The following is a description of a gene set: Human Gene Set: GSE3039_ALPHABETA_CD8_TCELL_VS_B2_BCELL_DN from publication Yamagata T, Benoist C, Mathis D (PMID 16623764) studied in species Homo sapiens Genes down-regulated in CD8A CD8B versus B2 B lymphocytes. Three innate (B1-B, NKT, CD8aaT cells) and adaptive (B2-B, CD4T, CD8abT cells) cell-types were sorted by FACS. Three biological replicates for NKT, CD4T, CD8aaT, CD8abT cells and two biological replicates for B1 and B2 cells were generated and the expression profiles were determined using Affymetrix Mu74Av2 chip. Comparisons between the sample groups allow the identification of genes differentially expressed between the innate and adaptive cell-types., and this is the list of marker genes: DYNLT3, IL1R2, NARS2, PLAC1, TNFRSF9, SRSF2, SRM, RMDN3, RARRES2, LOXL1, HOMER1, UQCRB, NUP93, UAP1L1, NFIL3, COQ7, TSC22D1, PRODH, CCL4 (NCBI Gene Id 6351), ACADS, PSMC3, PDE7B, SWI5, AP1B1, EXOC7, PEX11A, METAP2, POLR2D, TRIB2, PVT1, PFKM, ERBB3, EPRS1, MRPS10, KIF24, MCM6, RASSF8, PIGY, WDR12, ADAMTSL4, PPME1, PRDX6, COQ3, AKR1B15, TMEM147, DUSP6, POFUT2, RMDN2, MPHOSPH6, RNF19A, HAL, HSD3B7, TUBA1B, TTC1, MVK, SLC39A1, EBPL, SSX2IP, SLC25A1, FZD1, RENBP, LNX1, NUP88, TNS4, PRSS8, POLR2C, FADS3, HNRNPA1, ATP6V1H, PLAUR, ZNG1B, WDR74, BAIAP2, PSMB4, NUCB2, ARHGAP44, DPAGT1, RALB, PDLIM5, EXT2, SOWAHB, EVA1B, IL1B, PLAAT3, NAA20 (N-alpha-acetyltransferase 20, NatB catalytic subunit), SMURF1, WTIP, PSMD9, QKI (NCBI Gene Id 9444), HAUS1, ENO1, GCAT, DDRGK1, GPSM1, CNNM2, FNIP2, MRPL45, TIMM23, CENPE, RTEL1, BLOC1S5, PRR15, ME1, MYO5A, CENPI, CREB5, PGM1, CLEC5A, AIFM1, ERGIC1, PGF, TMED5, ALG11, MANF, TSG101, FCGR2A, ECHDC3, PEA15, ALKBH2, IL1RN, VPS53, ATIC, CCDC80, SNX8, INHBA (inhibin subunit beta A), SRPRA, APPL2, PPM1J, UBR3, PPP1R14C, LRRC58, MS4A7, ST7L, CHST1, TXNRD1, CLNS1A, TMLHE, NAGLU, MRTFB, TACC3, CENPP, P3H1, ATP7A, CENPS, SRC, TMED1, TADA2A, FUOM, FAM135A, ARHGEF19, GALNT7, IPO5, ELK3, DIO2, DAZAP1, WDR18, MYO1B, NCMAP, ZNF560, CCT2, CD164, METTL1, STMN1, PLEKHF1, DCUN1D3, NOL12, MTBP, BMP2K, ESYT2, COPG1, GARS1 (glycyl-tRNA synthetase 1), HDAC6, IDH2 (NCBI Gene Id 3418), AURKA, DYNC2H1, IGFBP6, LSM2, GINS1, TMEM165 (NCBI Gene Id 55858), TSEN2, MEGF8, THOC5, MET, SNX2, TSR1, PEBP1, REEP4, SBF2, AS3MT, NDUFA2, THOP1, GLO1 (glyoxalase I), RABGEF1, LRP12, NUBPL, GGT1, DSC2, ACADVL, SLC10A7, CENPW